Given this list of marker genes Il6st, 9930012K11Rik, Jrk, Kpna4, Itpr1 (NCBI Gene Id 18544), Gorab, Gm14137, Prkcb, 4933402D24Rik, Apbb2, Mbnl1, Adhfe1, Trp53inp1, Oaz2, Abcg8, Tsc22d2, Prkar2a, Slc25a23, Bmpr2, Dock5, Dact2 (NCBI Gene Id 73097), Rmi2, Hsd11b2, Heg1, Zswim9, Ttn, Pnkd, 1110059E24Rik, Mxd3, Zfp947 (NCBI Gene Id 210853), H2bw2, Kbtbd6 (NCBI Gene Id 432879), Lsamp, Gpr155, Arid3a, Entpd6, Prss39, Tmem216, Pcgf5, Jarid2, Laptm4b, Igsf11, Adpgk, Fasl, Bex3, Ess2, Map6, Tbc1d16 (NCBI Gene Id 328045), Vil1, Lrp2bp, Mmab, Pnoc, Ppfibp2, Txndc12 (thioredoxin domain containing 12 (endoplasmic reticulum)), Prr14l, Rab6a (RAB6A, member RAS oncogene family), Zfp189, Gm7616, Cop1, Capns2, Scyl1 (NCBI Gene Id 98159), G6pc2, Ccr9, Maged1 (NCBI Gene Id 94275), Saxo2, Ipcef1, Satb2, Clxn, Psmf1, Cdh7, AU018091, Szrd1, Il13ra1, Ap4s1, Pierce1, Apba1, Trpa1, Ptgfrn (NCBI Gene Id 99830), Rbbp7, Adgrd1, Zfp39, Pak5, Dynlt1a, Kctd21, Slc25a1, Maml3, Chst11, Greb1, Rubcn, Orai2, Lancl1, Pla2g4e, Mapk1ip1l, Lrrc47, Adora2a, Rnf150, Cyp26b1 (cytochrome P450, family 26, subfamily b, polypeptide 1), Cry2, Kcnk3, Gramd1a, Dcun1d5, 2510009E07Rik, Osbpl8, here is a description of the gene set: Genes predicted to be targets of miRBase v22 microRNA mmu_miR_7029_3p in miRDB v6.0 with MirTarget v4 prediction scores > 80 (high confidence targets). from publication Chen Y, Wang X (PMID 31504780) Mouse Gene Set: MIR_7029_3P species: Mus musculus